The following is a description of a gene set: Any process that stops, prevents, or reduces the frequency, rate or extent of Ras protein signal transduction. studied in species Mus musculus Mouse Gene Set: GOBP_NEGATIVE_REGULATION_OF_RAS_PROTEIN_SIGNAL_TRANSDUCTION, and this is the list of marker genes: Ppp2cb, Nup62, Spry2, Syngap1, Tnk1, Dgkz, Rasal1, Rasa2, Mfn2, Nf1, Rabgef1, Fbp1, Dab2ip, Lztr1, Mapkap1, Timp2, Rasa4, Stambp (NCBI Gene Id 78275), Ephb2, Rapgef1, Spry4, Tgfb2, Rasal3, Trim67, Spry1, Rasa3